Given this list of marker genes DFFA, REXO4, BAX, FOXL2, GATA5, DNASE2, DNASE1L1, DNASE1, APEX1, TREX2, APAF1, TREX1, ENDOG, DNASE1L2, NMNAT1, HSF1, CIDEA, MUS81, IL6, EXOG, CECR2, DICER1, FBH1, DNASE1L3, SETMAR, DFFB, VPS54, DNASE2B, ISG20, here is a description of the gene set: Human Gene Set: GOBP_DNA_CATABOLIC_PROCESS studied in species Homo sapiens The cellular DNA metabolic process resulting in the breakdown of DNA, deoxyribonucleic acid, one of the two main types of nucleic acid, consisting of a long unbranched macromolecule formed from one or two strands of linked deoxyribonucleotides, the 3'-phosphate group of each constituent deoxyribonucleotide being joined in 3',5'-phosphodiester linkage to the 5'-hydroxyl group of the deoxyribose moiety of the next one.